The following is a description of a gene set: studied in species Homo sapiens Genes down-regulated in NCAM+ NK cells: SELL bright versus SELL dim. Human Gene Set: GSE21774_CD56_BRIGHT_VS_DIM_CD62L_POSITIVE_NK_CELL_DN from publication Juelke K, Killig M, Luetke-Eversloh M, Parente E, Gruen J, Morandi B, Ferlazzo G, Thiel A, Schmitt-Knosalla I, Romagnani C (PMID 20505160) Human Natural Killer (NK) cells comprise two main subsets, CD56bright and CD56dim cells, that differ in function, phenotype and tissue localization. To further dissect the heterogeneity of CD56dim cells, we have performed transcriptome analysis and functional ex vivo characterization of human NK cell subsets according to the expression of markers related to differentiation, migration or competence. Here, we show for the first time that the ability to respond to cytokines or to activating receptors is mutually exclusive in almost all NK cells with the exception of CD56dim CD62L+ cells. Indeed, only these cells combine the ability to produce interferon (IFN)-gamma after cytokines and proliferate in vivo during viral infection with the capacity to kill and produce cytokines upon engagement of activating receptors. Therefore, CD56dim CD62L+ cells represent a unique subset of polyfunctional NK cells. Ex vivo analysis of their function, phenotype, telomere length, frequencies during ageing as well as transfer experiments of NK cell subsets into immunodeficient mice suggest that CD56dim CD62L+ cells represent an intermediate stage of NK cell maturation, which after restimulation can accomplish multiple tasks and further develop into terminally differentiated effectors., and this is the list of marker genes: FAAP24, AGAP1, CYTH3, SLC43A1, REXO2, SEPTIN8, MFAP4, E2F4, METTL16, SLC2A4, ATP1B2, CD40, BLVRB, GRB10, SPTA1, SLC23A3, NECAP2, SYCE3, KGD4, UROD, VSTM5, LEPROT, MRI1, NCBP2AS2 (NCBP2 antisense 2 (head to head)), DNAJC2, SLC36A3, BSND, ZDHHC14, SNHG17, PRPF4, SPATA16, POU3F3, POLR2J, FABP12, MST1R, HPN, UBAC1, NXPE4 (neurexophilin and PC-esterase domain family member 4), RRM2, APLP2, DAPK2, AK7, MRAP, EARS2, GAR1, MYH10, UROS, STK11, MYO1D, KHDRBS1, FAM241A, SETD4, TBCCD1, BTAF1, SLC22A23, DNAJC19, LTBP1, HYAL2, MDGA2, SCML2, TTLL12, USP36, PRDX6, MINPP1, MTHFD1, PBX4, APLN, UTP15, TIMM10 (translocase of inner mitochondrial membrane 10), FECH, COMMD5, DUSP10, TPRKB, DPY19L1, EPB41L5, FBXO31, C19orf67, CPT2, NECAB3, MGLL, SFXN2, CECR2, GCLM, EPDR1, NRIP3, REEP6, LAMA2, GFER, DHRS4, ATP13A3, BEX4, HACD1, PVT1 (NCBI Gene Id 5820), TPST1, TBRG4, HTRA2, LAMC2, IGF2R, SLC38A5, ATP5MC1, SH3TC2, SAMD1, ENDOD1, WSB2, RECQL4, G6PD, ALDH1A1, NUP214, TRMT61A, MCRIP2, TSPO2, DAXX, WDR91, EXOSC1, SNCA, ATL1, CAMSAP2, SCYL3, CALY, KLHL12, SACS, ZMAT3, GPR107, MUSTN1, MRPL54, AIF1, NKX1-2, CITED4, DAD1, GADD45GIP1, KLF1, TMED1, GAREM1, NXPE2, FUZ, SAC3D1, SGSM3, DPY19L4, DDIAS, GOLM1, EPOR, C5orf22, TRAPPC10, HEBP1, RPIA, ERCC6L, ST3GAL5, CTH, PWWP4, DNAJA3, POLR3E, UGCG, NUDCD2, SRP19, OAF, L3MBTL2, EMC9, PLXNA2, GZMH, CD82, JOSD2, ABCB6, AK5, METAP2, LHPP, RRP9, NEFL, VSX1, ADD2, ELL2, POP1, MRPS26, TENT5C, REPS2, ALKBH8, POLDIP2, HOXB13, OXNAD1, EXOC3, NOL9, B3GALT2, TYSND1, SLC16A10, XPNPEP1, MEIOB, SLC12A4, ATP5MG, C1orf50, CISD1, TEX9, STOM, STX2, PPM1L, KEL, C17orf99, ADGRE5, PABPC4, RBKS (NCBI Gene Id 64080), IBA57, RNF19A